Given this list of marker genes Sbp, Ctnnd1, Tmem114, Tjp1, Mtcl1, Fzd6, Krt8, Jup, Thbd, Sbpl, Mpdz, Slc28a2, Ocln, Rasgrf1, Cxadr, Cldn8, Slc28a2b, Ctnnb1, Cldn3, Krt19, Eppk1, Cldn4, Crb2, Cldn5, Cdh2, Prickle2, Cldn6, Palm, Cldn7, here is a description of the gene set: species: Mus musculus The apical end of the lateral plasma membrane of epithelial cells. Mouse Gene Set: GOCC_APICOLATERAL_PLASMA_MEMBRANE